The following is a description of a gene set: In an effort to identify genes whose expression is regulated by activated phosphatidylinositol 3-kinase (PI3K) signaling, we performed microarray analysis and subsequent quantitative reverse transcription-PCR on an isogenic set of PTEN gene-targeted human cancer cells. Numerous p53 effectors were upregulated following PTEN deletion, including p21, GDF15, PIG3, NOXA, and PLK2. Stable depletion of p53 led to reversion of the gene expression program. Western blots revealed that p53 was stabilized in HCT116 PTEN(-/-) cells via an Akt1-dependent and p14(ARF)-independent mechanism. Stable depletion of PTEN in untransformed human fibroblasts and epithelial cells also led to upregulation of p53 and senescence-like growth arrest. Simultaneous depletion of p53 rescued this phenotype, enabling PTEN-depleted cells to continue proliferating. Next, we tested whether oncogenic PIK3CA, like inactivated PTEN, could activate p53. Retroviral expression of oncogenic human PIK3CA in MCF10A cells led to activation of p53 and upregulation of p53-regulated genes. Stable depletion of p53 reversed these PIK3CA-induced expression changes and synergized with oncogenic PIK3CA in inducing anchorage-independent growth. Finally, targeted deletion of an endogenous allele of oncogenic, but not wild-type, PIK3CA in a human cancer cell line led to a reduction in p53 levels and a decrease in the expression of p53-regulated genes. These studies demonstrate that activation of PI3K signaling by mutations in PTEN or PIK3CA can lead to activation of p53-mediated growth suppression in human cells, indicating that p53 can function as a brake on phosphatidylinositol (3,4,5)-triphosphate-induced mitogenesis during human cancer pathogenesis. studied in species Homo sapiens Genes down-regulated in HCT116 cells (colorectal carcinoma) upon knockout of PTEN. Human Gene Set: KIM_PTEN_TARGETS_DN from publication Kim JS, Lee C, Bonifant CL, Ressom H, Waldman T (PMID 17060456), and this is the list of marker genes: RBM4, RIT2 (NCBI Gene Id 6014), PTEN, ZNF574, MGA (MAX dimerization protein MGA)